Given this list of marker genes PTER (phosphotriesterase related), RPSAP7 (ribosomal protein SA pseudogene 7), RPP38-DT, RSU1, ITGA8, NMT2, RNU2-18P, MCM10, FAM171A1, CAMK1D, ACBD7, FRMD4A-AS1, VIM-AS1, BEND7-DT, FRMD4A, RNA5SP302, TRDMT1, OR7E115P (NCBI Gene Id 81353, olfactory receptor family 7 subfamily E member 115 pseudogene), OR7E110P, SUV39H2, RPP38, FTLP19, MIR548Q, PPIAP30, MEIG1, PRPF18, CUBN (cubilin), FAM107B, MIR4480, ENSG00000293819, MIR1265, ENSG00000286514, DCLRE1C (NCBI Gene Id 64421), RNA5SP301, GAPDHP45, RPL6P24, MIR4481, PHYH, VIM, CCDC3, SNRPGP5, HSPA14, LINC02654, RNU6ATAC39P (RNA, U6atac small nuclear 39, pseudogene), CDNF, ENSG00000236495, SEPHS1, SUV39H2-DT, RPL5P25, MINDY3, OLAH, BEND7, MIR4293, OR7E26P, RNA5SP300, UCMA, RNU6-6P, DCLRE1CP1, C1QL3, RNU6-1075P, RN7SL198P, RBISP1, NUTF2P5, OPTN, BTBD7P1, MSANTD7, RPL36AP36, here is a description of the gene set: Human Gene Set: chr10p13 species: Homo sapiens